Given this list of marker genes JUN, MAPK14, MAPK10, FOS, MAPK1, MAPK8, MAPK9, MAPK3, MAPK11, ATF2, here is a description of the gene set: species: Homo sapiens Activator protein-1 (AP-1) is a collective term referring to a group of transcription factors that bind to promoters of target genes in a sequence-specific manner. AP-1 family consists of hetero- and homodimers of bZIP (basic region leucine zipper) proteins, mainly of Jun-Jun, Jun-Fos or Jun-ATF. <p>AP-1 members are involved in the regulation of a number of cellular processes including cell growth, proliferation, survival, apoptosis, differentiation, cell migration. The ability of a single transcription factor to determine a cell fate critically depends on the relative abundance of AP-1 subunits, the composition of AP-1 dimers, the quality of stimulus, the cell type, the co-factor assembly. </p><p>AP-1 activity is regulated on multiple levels; transcriptional, translational and post-translational control mechanisms contribute to the balanced production of AP-1 proteins and their functions. Briefly, regulation occurs through:<ol><li>effects on jun, fos, atf gene transcription and mRNA turnover.<li> AP-1 protein members turnover. <li>post-translational modifications of AP-1 proteins that modulate their transactivation potential (effect of protein kinases or phosphatases).<li>interactions with other transcription factors that can either induce or interfere with AP-1 activity.</ol> part of: MAPK targets/ Nuclear events mediated by MAP kinases Reactome Pathway: Activation of the AP-1 family of transcription factors